The following is a description of a gene set: Human Gene Set: GAVISH_3CA_METAPROGRAM_CD4_T_CELLS_STRESS_HSP Genes upregulated in subsets of cells of a given type within various tumors In this study, an extensive analysis was conducted to define meta-programs (MPs) capturing intra-tumor heterogeneity across a spectrum of tumor types. The approach utilized non-negative matrix factorization (NMF) to analyze each cell type separately within individual tumor samples. This involved the analysis of malignant cells, macrophages, fibroblasts, endothelial cells, epithelial cells, T-cells, and B-cells. NMF was executed with varying parameter values (K=4, 5, 6, 7, 8, 9), thereby generating 39 programs for each cell type per sample. Each NMF program was summarized by the top genes based on NMF coefficients.\nRobust MPs were then delineated for each cell type using a set of stringent criteria, including recurrence within the same tumor, similarity to programs in other tumors, and non-redundancy within a tumor. Subsequently, these robust NMF programs were clustered (per cell type) based on Jaccard similarity, leading to the identification of MPs associated with each cell type.\nTo enhance the quality of the MPs, a refinement steps were undertaken, involving the removal of MPs suspected of reflecting low-quality data (with an overrepresentation of ribosomal proteins or mitochondrial-encoded genes), single-study inclusion, or similarity to miss-annotated cell types. from publication Gavish A, Tyler M, Greenwald AC, Hoefflin R, Simkin D, Tschernichovsky R, Galili Darnell N, Somech E, Barbolin C, Antman T, Kovarsky D, Barrett T, Gonzalez Castro LN, Halder D, Chanoch-Myers R, Laffy J, Mints M, Wider A, Tal R, Spitzer A, Hara T, Raitses-Gurevich M, Stossel C, Golan T, Tirosh A, Suvà ML, Puram SV, Tirosh I (PMID 37258682) species: Homo sapiens, and this is the list of marker genes: DOK2, RGS2, CACYBP, DNAJB4, HSPD1, ODC1, HSPA1B, DNAJB1, SERPINH1, CCL20, TCP1, ID2, GEM, CLK1, FKBP4, HSPA6 (NCBI Gene Id 3310), PMAIP1, JUN, PLIN2, CHORDC1, HSP90AA1, BAG3, HSPB1, DEDD2, AHSA1, REL, HSPA1A, MYLIP, HBP1, HSP90AB1, PPP1R15A, FABP5, ANXA1 (NCBI Gene Id 301), TSPYL2, DNAJA4, NEU1, JUNB, SQSTM1, IRF1, DNAJA1, DUSP1, NUDC, MRPL18, BTG2, ZFAND2A, SOCS3, TRA2B, GADD45B, HSPH1, HSPE1